The following is a description of a gene set: Any process that activates or increases the frequency, rate or extent of membrane invagination. studied in species Mus musculus Mouse Gene Set: GOBP_POSITIVE_REGULATION_OF_MEMBRANE_INVAGINATION, and this is the list of marker genes: F2rl1, Abca7 (NCBI Gene Id 27403), Trem2, Plcg2, Ano6, Lbp, Stap1, Appl2, Fcgr1, Itga2, Pparg, Ager, Cd36, Gata2, Rab31, Nckap1l, C3